Given this list of marker genes TNNC2, KPNA3, RTL3, CDC42EP3, KCNJ9, TPM2, GPC4, ARR3, PCDH9, LIF, GPR153, ITGA7 (integrin subunit alpha 7), ARHGAP26, VEZF1 (vascular endothelial zinc finger 1), ATXN1 (ataxin 1), TTYH2, RALY, SLC32A1, RASGEF1B, TNNI3K, GRIN2B, ARMCX6, TRDN, CARTPT, SLC8A3, KLHL41 (NCBI Gene Id 10324), FBXW11, MID1IP1, HJV, LUC7L, CUX1, SLAMF1, LZTS2, TSPEAR, TCEA3, THBS2, DKK2, HAS2, KCNQ5, FILIP1, SLC30A1, RNF145 (ring finger protein 145), HOXC4, CPEB4 (NCBI Gene Id 80315), FGF12, ATP1B2, IRS1, DIRAS1, WFDC1, NME5, SSPN (sarcospan), SMYD1, TRIM55 (tripartite motif containing 55), PDLIM1, ERG, KLF14, PLEKHA6, MEOX2, TWIST1, PTCHD4, KLHL40, NR2F1, NRXN3, SMARCA2, HS3ST5, CASQ1, CKM, TPP2, DNAJA4, HIBADH, NR4A1, CAPN3, ADGRB3, PLAGL2, ESAM, MYF6, ZFPM2, SCAI, TYRO3, MYL1, JMJD1C, KTN1, BZW2, PRMT3, CTNND2, HOXD4, SMPX, PCBP2, SOX5 (NCBI Gene Id 6660), TP63, ASB16, SLC29A2, STAC, ZNF385B, BCL9L, DMD, DLG2, CA7, EEF1AKMT1, TMEM71, ARHGEF38, CASQ2 (NCBI Gene Id 845), SSH3, CCDC140, MYOZ2, SDHC, CACNA2D3, VSIG1, PRKAG1, EPHA7, CELF4, FITM1, ATP2A3, LYN, TSPAN13, HDAC7, CNMD, TGFB3, ASPH, AMPD1, NFAT5, EYA1, TRPS1, PTPRO, MOSMO, PAK6, GABRB2, B3GLCT (beta 3-glucosyltransferase), TSC22D1, USP2, SMIM8, WBP4, NDP, SLC2A4, MYL2, LINC01597, MAB21L2, HAO1, ART5, MAP2K5, GET4, MRPS23, TNNC1, FAM117A, MITF, PYY2, MGST3, EEF1A2, ZFAND5 (NCBI Gene Id 7763), FBXO40, STOML2, TRAK2, S1PR1, NCAN, RAP2C, SLCO3A1, HAPLN1, TAF5L, TRMT10A, RAB2A, SCML1, NEDD4, ARHGAP36, YJEFN3, SLC26A6, KRT222, ZHX2, ANKMY2, SLCO2A1, KCNN1, TNFRSF17, ESR1, PTCH1, RGS3, ITGB3BP, MUSK, COL8A1, BNIP3, PRDM1, HDAC9, RIPOR1 (RHO family interacting cell polarization regulator 1), PDGFRA, ZNF143, PIK3R3, CRTAP, ELAVL4, RASGRP3, ADAM11, KY, SLC26A9, CNTN1, ARHGEF37, TNNI1, SV2A, PTPN1, TRIM33, ACTC1, KLHDC8B (NCBI Gene Id 200942), PMEPA1, POU4F1, MYL3, CLRN1, NEXN-AS1, ARHGEF15, CYP2E1, INPP4A, MBNL2, DTNB, CLCN1, ATF3, POFUT1, BNC2, RTL9, PAX3, STRADB, MYH4, DGKI, CUL3, here is a description of the gene set: studied in species Homo sapiens Human Gene Set: RSRFC4_Q2 Genes having at least one occurrence of the motif ANKCTAWAAATAGMHNN in the regions spanning 4 kb centered on their transcription starting sites. This matches the MEF2A transcription factor binding site V$RSRFC4_Q2 (v7.4 TRANSFAC).